Given this list of marker genes PDE2A, SCN8A (sodium voltage-gated channel alpha subunit 8), SCN2A, KCNQ2, KCNQ3, PRRT2, here is a description of the gene set: Lack of observable abnormal electroencephalographic (EEG) patterns in an individual with a history of seizures. About half of individuals with epilepsy show interictal epileptiform discharges upon the first investigation. The yield can be increased by repeated studies, sleep studies, or by ambulatory EEG recordings over 24 hours. Normal interictal EEG is a sign that can be useful in the differential diagnosis. studied in species Homo sapiens Human Gene Set: HP_NORMAL_INTERICTAL_EEG Normal interictal EEG